The following is a description of a gene set: from publication Cao J, O'Day DR, Pliner HA, Kingsley PD, Deng M, Daza RM, Zager MA, Aldinger KA, Blecher-Gonen R, Zhang F, Spielmann M, Palis J, Doherty D, Steemers FJ, Glass IA, Trapnell C, Shendure J (PMID 33184181) studied in species Homo sapiens Marker genes curated from the annotated cluster as represented in the Descartes Human Gene Expression During Development database. Human Gene Set: DESCARTES_FETAL_HEART_VISCERAL_NEURONS The gene expression program underlying the specification of human cell types is of fundamental interest. The study authors generated human cell atlases of gene expression and chromatin accessibility in fetal tissues. For gene expression, the study authors applied three-level combinatorial indexing to >110 samples representing 15 organs, ultimately profiling ~4 million single cells. The study authors leveraged the literature and other atlases to identify and annotate hundreds of cell types and subtypes, both within and across tissues. Our analyses focused on organ-specific specializations of broadly distributed cell types (such as blood, endothelial, and epithelial), sites of fetal erythropoiesis (which notably included the adrenal gland), and integration with mouse developmental atlases (such as conserved specification of blood cells). These data represent a rich resource for the exploration of in vivo human gene expression in diverse tissues and cell types., and this is the list of marker genes: CAMK2N2, LINC02691, FGF14-IT1, ST8SIA3, MAB21L2, KCNH1, PTPRR, GNG4, TMC3, FAM163A, PRUNE2, CPEB1, SLC6A2, NXPH1, RAB3B, PCBP3, EML5 (EMAP like 5), SCG2, TH, EYA4 (EYA transcriptional coactivator and phosphatase 4), CHRM1, PHOX2A, ASTN2, LINC01561, GAL, PHOX2B, PHOX2B-AS1, PHYHIPL, CHRNB4, CA10, SLC10A4, NPY2R, ISL1-DT, SYT9, C14orf132, SPOCK3, PIRT, CHGB, SLC7A14, MYT1, TMEM130, LINC01250, DBH, NEFH, STAC, RGS9, ISL1, SEMA4F, MAB21L1, GATA3-AS1, GALR1, KCNK12 (potassium two pore domain channel subfamily K member 12), ELAVL2, PLPP4, RAB3C, KCTD16, SLC18A3, ECEL1 (NCBI Gene Id 94923), VGF, ZCCHC12, HCN2, SST, GRM8, ACHE, C14orf39, DDC, PRPH, SLC18A1, FST, CHRNA7, CNTN5, ELAVL4, CHRNA3, NECAB2, RAB39B, SLC5A7, LINC03000, ENSG00000260917, OPRM1, TMEM255A, NPM2, RGS4, FAM167A, FNDC9, LGI3, PIANP, KCNK3